The following is a description of a gene set: The process whose specific outcome is the progression of a mesonephric duct over time, from its initial formation to a mature structure. A mesonephric duct is a tube drains the mesonephros. Human Gene Set: GOBP_MESONEPHRIC_DUCT_DEVELOPMENT studied in species Homo sapiens, and this is the list of marker genes: WNT11, OSR1, GREB1L, GPC3, LHX1, PKD2 (NCBI Gene Id 5311), HNF1B, WNT9B, PKD1